The following is a description of a gene set: Defective B4GALT1 causes B4GALT1-CDG (CDG-2d) species: Homo sapiens Human Gene Set: REACTOME_DEFECTIVE_B4GALT1_CAUSES_B4GALT1_CDG_CDG_2D, and this is the list of marker genes: ACAN, KERA, B4GALT1, LUM, OGN, OMD, FMOD, PRELP